Given this list of marker genes IL1RN, ETV3, KITLG, AXIN2, VAMP8, SRPK3, NOS2, HINFP, MTFR2, PDZK1, PARD3B, E2F8, CRBN, CNMD, USP15, CCNL1, PSMB8, SAP30, CXCL9, TUBG2, HK2, SELENOW, SH3TC1, PROCR, GTPBP2, LNX1, HOMER1 (homer scaffold protein 1), CCNJ, ATP8B3, PCDH8, RNF17, LAP3, DUSP16 (NCBI Gene Id 80824), EBI3, TTYH2, TMEM106A, PC, RBM43 (NCBI Gene Id 389054), GALR3, SLC28A2, PLAGL2, ATF7, ZNF318, LRRC23, CRK, IL10RB, CRYM, CLK3, HSPB3, F7, TRIB2, CA1, BCL2L1, TACR2, C11orf68, RBM8A, MMP2, IRGM, OCIAD1, PALLD, LRRN1, PADI3, MAGED2, PTPRE, CSN2, PTPN6, CCDC6, MAPK10, CACNA1D, TRIM25, LZTFL1 (leucine zipper transcription factor like 1), FGF18, CCDC9, TIMP1 (NCBI Gene Id 7076), RPAP1, ITPR1, TMEM39A, ACSS1 (acyl-CoA synthetase short chain family member 1), JAK2, POLR3F, SGCA, PRKD1, SH3BP1, GATAD2B, PKDCC, RGL1, WNK4 (NCBI Gene Id 84361), SNX16, EDNRA, CCNE1, TSSK2, CCL13, MSLN, GPN2, KLF5, VRK2, GCC1 (GRIP and coiled-coil domain containing 1), SLC6A4 (NCBI Gene Id 6532), KRTDAP, MELTF, BLOC1S4, IDO2, BFAR, DAB2, CYTH1, SLC6A8, KLRK1, ZBTB7A (NCBI Gene Id 56976), RYR2, SLC31A1, TRIM34 (NCBI Gene Id 53840), INHBB (NCBI Gene Id 3625), STXBP3, SPRYD7, STAT5A, RANBP1 (RAN binding protein 1), CAPN5, WDR54, PCDHB10, RHOG, EPSTI1, CD79A, GK, BCDIN3D, PPP1R15B, HSPA2, MAP3K5, MACROH2A1, ENDOD1, IER3, CD70, COL9A1, PML, SERTAD1 (NCBI Gene Id 29950), ADH7, PARG, MCMBP, LMBR1L, SLAMF9, SLC12A9, STK31, PLCG1 (NCBI Gene Id 5335), DYRK1A, DHX58, ASB6, HMGA1, GFPT1, CGA, ACTN1, VCL, FBXW11, BST2, MDFIC, BNIP2, RND3, FLNC, TBC1D13, PLAC8, TSPAN10, IGSF8, BLOC1S6, NOTCH1, TYK2, ADORA1, ITGA4, DDX4, CHD1, LGALS8, ADCY2, HAT1, CAV1, GATAD2A, SLC26A2, CDH6, DDHD1, G3BP2 (G3BP stress granule assembly factor 2), MOB4, KEAP1, FHL5 (four and a half LIM domains 5), TBL1X, GCA, M1AP, PHC2, SERPINB9, MEP1B, EIF2S2, MS4A6A, NDP, LMO4, HDAC1, PHOX2A, SLC47A1, STARD3, ARPC5, SLTM, OTC, VPS72, FOXD1, DDIT3, here is a description of the gene set: Genes down-regulated in comparison of control dendritic cells (DC) at 8 h versus those stimulated with poly(I:C) (TLR3 agonist) at 8 h. Human Gene Set: GSE17721_CTRL_VS_POLYIC_8H_BMDC_DN studied in species Homo sapiens mouse primary BMDCs were stimulated with tlr ligands and gene expression changes were profiled on Affymetrix arrays from publication Amit I, Garber M, Chevrier N, Leite AP, Donner Y, Eisenhaure T, Guttman M, Grenier JK, Li W, Zuk O, Schubert LA, Birditt B, Shay T, Goren A, Zhang X, Smith Z, Deering R, McDonald RC, Cabili M, Bernstein BE, Rinn JL, Meissner A, Root DE, Hacohen N, Regev A (PMID 19729616)